The following is a description of a gene set: Mouse Gene Set: LIN_NPAS4_TARGETS_UP species: Mus musculus Genes up-regulated in neurons after NPAS4 knockdown by RNAi. from publication Lin Y, Bloodgood BL, Hauser JL, Lapan AD, Koon AC, Kim TK, Hu LS, Malik AN, Greenberg ME (PMID 18815592) Neuronal activity regulates the development and maturation of excitatory and inhibitory synapses in the mammalian brain. Several recent studies have identified signalling networks within neurons that control excitatory synapse development. However, less is known about the molecular mechanisms that regulate the activity-dependent development of GABA (gamma-aminobutyric acid)-releasing inhibitory synapses. Here we report the identification of a transcription factor, Npas4, that plays a role in the development of inhibitory synapses by regulating the expression of activity-dependent genes, which in turn control the number of GABA-releasing synapses that form on excitatory neurons. These findings demonstrate that the activity-dependent gene program regulates inhibitory synapse development, and suggest a new role for this program in controlling the homeostatic balance between synaptic excitation and inhibition., and this is the list of marker genes: Matcap1, Lrfn1, B4galt3, Tigar, Pfkfb4, Tbck (TBC1 domain containing kinase), Lpl, Gmps, Cct7, Ttyh1, Nans, Clmp, Rbbp6 (retinoblastoma binding protein 6, ubiquitin ligase), Pex14 (peroxisomal biogenesis factor 14), Gmcl1 (germ cell-less, spermatogenesis associated 1), Nedd4l, Gramd4, Pnpla6, Tmem74, Fbxo8, Ppp1r11, Chodl, Ap4e1, Chmp7, Spock2, Celf6, Ap2b1, Itpk1 (NCBI Gene Id 217837), Cfap418, Nrsn1, Nelfb, Nip7, Gnpda1, Fam107b, Abcf1, Tdg (NCBI Gene Id 21665), Arhgef7, Bzw2, 1810009A15Rik, Lrsam1, Lnpep, Eps15, Tmem267, Rrn3, B3galnt1, Fam81a, Arhgap20, Trim67, Sec61a1 (NCBI Gene Id 53976), Fam210a, Fam234a (family with sequence similarity 234, member A), Ginm1, Epas1, Hs2st1, Dnajc27, Mras, Rnf152, Mkrn3, Fam8a1, Slc35a1, Xkr6, Rpl39l, Mpp3, Lpgat1, Ptpa, Vps26c, Soat1, Dhx40, Kif3b, Gabrb2, Gprin2, Sgk1, Marchf8, Panx1, Ptp4a1, Kif26b, Mtx3, Actr10, Atp2c1, Mllt1, Akt3, Rab3b, H2-K1 (histocompatibility 2, K1, K region), Hspa1a, Gria3, Marchf9, Mb21d2, St6gal1, Serbp1, Slc8a1, Ahi1, Rab2b, Dars1, Pnma2, Rcan1, Chmp2b, Mok, Cdc42ep2, Mycl, Gm35161, Nup155 (NCBI Gene Id 170762), Slc24a3, Pcsk2, Mtfp1, Rps6ka3, Sephs2, Scn3a, Prkab2, Fxyd6, Vcpip1, Spryd7, Pomk, Dhcr24, Acot7, Naa15, Ntrk3, Prkaa2, Asb1, Samd12, Zdhhc7, Plcxd3, Msi1, Ppp1r3e, Stxbp5, Snap47, 5031425E22Rik, Impa1, Cep15, Cdc42se2, Gabrb1, Ogfrl1, Mllt3, Pcdh17, Usf1, Capn7 (NCBI Gene Id 12339), Ddhd2, Fam32a, Cdkn1b, 2510009E07Rik, Lrrc3, Ak4, Kcnk9 (potassium channel, subfamily K, member 9), Mfsd6, D130043K22Rik, Zbtb6, Ift43, Tmed8, Chmp4b, Smim14 (NCBI Gene Id 71403), Ago2, Tmem8b, 1700066M21Rik, Rasgrf2, Smug1, Slc9a9, Rbm4 (NCBI Gene Id 19653), 1700061N14Rik, Tspyl3, Cfap97, Tstd3, Aldh1l2, Pkia, Ccng1, Dmac2l, Lypd6 (LY6/PLAUR domain containing 6), Slc27a4, Rbm34, Camsap1, Hsdl1, Slf1, Add2, Bsdc1 (BSD domain containing 1), Cdk14, Rnf182